Given this list of marker genes CYP46A1, CANX, CAMK2D, MAPK14, MECP2, EPN2, MXI1, USP6, NDUFA4L2, USP32P2, BCL11B, FOXO4, DHRS11, CAMK2N2, SOBP, CITED2, FIGN, RANBP9, FZD8, OTUD5, CREB1, PMP22, OTUD4, KHDRBS1, PCDH9, RTF1, RUNX1, CNIH1, CYFIP2 (NCBI Gene Id 81032), GDA, SLC18A2, MYCN, B4GALT1, USP47, VEZT, KRAS, ATP2B1, UBR3, MBNL1, ZMYND11, LRCH1, H2AZ2, MAFB, MSL2, EIF3A, SON, UBE2D3, CELF1, CBX6, ARHGAP26, SLC25A3, AGFG2, TTBK2, SH3RF1, USP32, SAMTOR, HUWE1, ZNF609, ALS2, HIPK1, IRF2BPL, SIRPA, YTHDF3, CTDSPL, GPR85 (NCBI Gene Id 54329), BOLA2, DDX3Y, NFE2L1, RREB1, YPEL5, GLP1R, DHX15, CCDC178, ELAVL2, CEP44 (NCBI Gene Id 80817), BICD2, SRGAP2, TBL1XR1, SLC12A2, TMEM263, STRN3, SIRT3, CGGBP1, TAFA5, MKRN1, KCNJ2, ATP2B2, SRSF1, PDPK1, RNF44, AKAP1, ZIC2, BMAL1, PABIR1, DDX3X, PDE4D, KIAA0408, GCC1, LIN28A, SELENOI, ZBTB18, DPYSL3, PALM2AKAP2, GPBP1, here is a description of the gene set: Human Gene Set: GTGTTGA_MIR505 studied in species Homo sapiens Genes having at least one occurence of the motif GTGTTGA in their 3' untranslated region. The motif represents putative target (that is, seed match) of human mature miRNA hsa-miR-505 (v7.1 miRBase).